The following is a description of a gene set: species: Homo sapiens Developmental hypoplasia of the dens of the axis. Hypoplasia of the odontoid process Human Gene Set: HP_HYPOPLASIA_OF_THE_ODONTOID_PROCESS, and this is the list of marker genes: RAB33B, IARS2 (isoleucyl-tRNA synthetase 2, mitochondrial), GNPTAB, COL2A1, COG4, NFIX, FN1, GLB1, LFNG, GUSB, IDUA, TRAPPC2, LONP1, RMRP, EIF2AK3, INPPL1, TRPV4, COMP, GALNS (NCBI Gene Id 2588), EXTL3, AIFM1, FLNB, FGD1, ARSB, DYM, DDR2, BGN